Given this list of marker genes MYCNOS, VPS41 (VPS41 subunit of HOPS complex), IL18RAP, CRISP2, PHKG2, C1orf21, IPO8, LDB2, NPY5R, SYT11, SERPINC1, MATN4 (NCBI Gene Id 8785), LCAT, CRYBB3, GRM8, PRORP, BTBD9, ANGPTL7, GK2, KIF1A, EPHA7, CTRB1, DOC2A, RBM17 (RNA binding motif protein 17), CXCL6, DKFZP434A062, TEKT2, CDKN2B, ZNF239, CHRNA1, NTN3 (netrin 3), MYBPH, OPHN1, ADAM7, MLLT3, CST5, AKAP5, CA5A, SEC14L2, DMP1, RFX1, GUCA2A, VIPR2, KIF17, BRDT, NLE1, MUC7, SPOCK3, WNT1, MT1B, SCN2A (NCBI Gene Id 94312), BHMT, RPGRIP1, MAP3K14, BTC, HIPK2 (NCBI Gene Id 653052), HOXD9, BAAT, FSTL4, ASTN1, CUL3, DCAF4, RAB3A, CRISP1, SMG6, TNFSF11, NEU3, KIT, DSC1, TCF15, MYH7, PDE9A, FOXN2, CYP1A2, UGT2B4, FOXH1, ZNF208, CD3G, EIF2B1, SPAM1, PDE6C, IRGC, ZFY, AKR1C4 (aldo-keto reductase family 1 member C4), ARK2N, SOX3, OPN1SW, SOS1, XPNPEP2, OPRPN, CYP4F11, ATRNL1, NACAD, CBLIF, GABRA6 (NCBI Gene Id 2559), PTGDR2, IFNA4, MPHOSPH8, KCNA3 (NCBI Gene Id 3738), ODF2, KRT37, ZNF264, SAA4, DOHH, ATP2A1 (NCBI Gene Id 487), CYTH3, SLITRK2, ART3, RASGRF1, ZNF154, COX10, AP4E1, P2RY6, ORC4, AVPR1A, MTRF1L, CHM, YJU2, GPR176, C9, KCNH1, here is a description of the gene set: Neighborhood of MAP3K14 Human Gene Set: MORF_MAP3K14 species: Homo sapiens Neighborhood of MAP3K14 mitogen-activated protein kinase kinase kinase 14 in the MORF expression compendium